Given this list of marker genes TMEM40, TPK1, SPACA6, TBC1D9B, CHAMP1, ZNF780B, APC2, CSNK1G1, ERF, ZNF564, ERCC6, RCHY1, CLEC11A, MGLL, HAUS3, TMEM184C-DT, PDGFA, DMAP1, OMA1, SPOCD1, ITGB3BP, FER, ZNF566-AS1, GLMN, TBX2-AS1, DGKA, CMC1, CAPN14, GREM1, TLCD5, MICD, SH2D5, PACS1, CCDC171, ZNF546, ZNF736, RN7SL685P, PLEKHM1, REXO4, GID4, MT-ND5, KARS1P1, DDHD2, THAP6, SMG5 (SMG5 nonsense mediated mRNA decay factor), RNF32, USP32, ZNF516, LAMA4, RHBDL1, PPP1R21-DT, CSPG4, C12orf76, SPTLC1P1, PNMT, POLE4, TPTEP2, GFPT2, RN7SL552P, RBM48, LGALS3, TTC23L-AS1, ENSG00000207751, ZNF384, ECI1-AS1, ST14, NPLOC4, ZNF234, JPH4, IPO5, SPEF2, LIM2, EPHX1, PEX5, PCLAF, SLC4A1AP (NCBI Gene Id 55189), PLEKHH2, SH3GL1, ZNF688, CPLX2, EMC4 (NCBI Gene Id 51234), CSK, VIRMA, WLS (Wnt ligand secretion mediator), LINC01168, CFAP418-AS1, ARFGAP2 (NCBI Gene Id 84364), MARCHF6, ESYT1, SLC35E1P1, RNU6ATAC34P, ENSG00000232995, DISC1, HNRNPR, MRPL55, APEH, CCNT2, STK19, AGPAT3, DDX31, ETFB, ABLIM2, COQ8B, TFEB, TNKS, PACRGL, ATP5PD, RAB11A, ERICH6, CCDC159, ODAD3, ISY1-RAB43, CUX1, SQSTM1, IDH1, DCTN2, LINC00847, SAP30L, NKPD1, USP8, LARP7, ZNF100, L3MBTL3, ZEB2, ABCA7, METTL9, NFATC4, ZNF568, ZNF227, PRCC, MGRN1, PICART1, TAFA2, WDR36, HS3ST3B1, PHLDA1-AS1, RIPOR1, ARID4B, WSCD2, TEFM, CNN3-DT, RBM42, ZNF146, SLC11A2, ZNF302, RNU6-234P, CAAP1, MICAL1, MPP7-DT, CCDC178, INO80D, RPL38, CEP192-DT, CAP1P2, LINC01273, ULBP1, CHRM1, FDFT1, KRT86, LIG4, TMEM184C, MTG1 (NCBI Gene Id 92170), DAP3, ZNF566, PCK2, ARHGEF10, OGG1, MDM2, MDM4, ULK1, CPXCR1, METTL4, PWWP3A, HMGB1, H3P10, ZNHIT6 (zinc finger HIT-type containing 6), KPNB1, DAD1, OSBPL11, TNFAIP1, ENSG00000272473, LINC00662, FRA10AC1, RNVU1-34, VIRMA-DT, SEC14L1, ABAT (NCBI Gene Id 731754), MRPL41, PHF3, SRRM2, CPNE1, VPS13B-DT, ZNF155 (zinc finger protein 155), ZNF569, LINC01972, ANGEL2, SLC9A7, USP15, CEP85, FGGY, MT-ND4L, SYNGAP1, TBPL1, CCN3, DPM3, ASGR1, DDX21, CFL1, NAA30, ELOC, RPL27A, MRPS31P5, KDM5A, LINC01549, MTF2, CYREN, FOXJ3, TTC41P, MAP3K14-AS1, ICA1L, ELAPOR1, SV2B, CRKL, STAT4, PTPRK, MTCL1, RSAD2, NDC80, ZNF25-DT, ALG10B, MAGOH2P, ANK2, GABPB2, CHUK-DT, ING2, TMEM225B, MPI, ZNF292, MSX1, CYP2F1, WDR11-DT, ZNF829, SRP54-AS1, EBNA1BP2, RNU6-362P, RMND1, RAB4B, ZNF540, DNAAF5, NADK, AFMID, HOXB3, NUDT3, KCNA1, LAMTOR5, ZNF233, PPIH, HMGN4, PPP1R21, MIR1301, SMYD4, RNU2-32P, MYLK, MAN2C1, PSMC3IP, TAOK2, SLC35E4, ATPAF2 (ATP synthase mitochondrial F1 complex assembly factor 2), NEO1, ALS2, REST, EXOSC3, CYP24A1, ERICH6-AS1, ACO1, MAX, TMT1B, LINC00173, ZC3H10, NR2F1, TTI2, COPS4, C8orf82, JPX (JPX transcript, XIST activator), ADGRF3, ZNF274, IFT20, MRPS31P4, ATP10D, MIR4794, SNRPCP3, RCAN1, ZNF33A, MIR3186, MIR9-1HG, CDKL2, FALEC, ACER3, NOTCH3, LINC01353, FAM8A6P (NCBI Gene Id 114182), DIS3L2, SULT2B1, MSRA-DT, MIR3677HG, TXNDC12, RNU6-738P, ILVBL, CCDC183, DIXDC1, ARHGAP1, MEIS1-AS2, HK2-DT (NCBI Gene Id 118568819), GPR146, RXFP4, RAI14, TMTC2, VWA8, EIF4G3, SLC39A3, NIM1K, PRKAG2, PSMD8, RPL6, SFXN1, SLC35A4, CTBP2P7, ENSG00000273523, TRPC6P2, SNX11, SLC12A7, MACROH2A2, MIR1193, LINC02361 (NCBI Gene Id 100996246), KCTD13-DT, CACNA1G, CCDC8, GBA1, EHHADH, SARS2, RELT, HACD3, AATBC, ZMPSTE24-DT, KLF13, BRD3, TGFA, MSMP, AATK, SHB, PKMYT1AR, NDUFA13 (NADH:ubiquinone oxidoreductase subunit A13), RPS27L, RPL12P37, ELFN2, RPS21P7, C1QTNF12, BIVM (NCBI Gene Id 54841), TASOR2, GALNT2, RPH3AL, PSMD6, HOXB-AS3, RNF145, TMEM69, ZNF37A, MIR663AHG (MIR663A host gene), ZNF433-AS1, SLK, RC3H1, TAF13, TPBG, ALOX12B, ZNF567 (zinc finger protein 567), ZNF438, LMNB1, FYCO1, GGT6, SAGE1, FKBP9, MORC2, RPL4, PMEPA1, DCAKD, HNRNPM, KCND3-AS1, PEX11G, ATP13A2, PRMT1, ZSCAN16-AS1, PML, ZBTB45, PLEKHG5, AKR7A2, SEPTIN5, BRD4, SMG1P2, DNAI4, SLC7A6, CBLN3, RN7SL45P, NR2E3, CDC42EP4, CISD1, HSP90B1, TTF2, STX1B, MCM3AP, NKAP, FRAS1, ZNF217 (zinc finger protein 217), ARB2A, TMEM70, NDRG2, CGGBP1 (CGG triplet repeat binding protein 1), RAD23B, KRR1, PIEZO1, MAGIX, CECR2, NDUFAF1, CFAP144, LRIG2, PCBP4, CNN3, ACD, LARP4, SSC5D, ZBED3-AS1, DPY19L3-DT, RDM1 (RAD52 motif containing 1), ENSG00000275465, BCAR1, HSPB1, ATG12, SREK1, MTA1, SFTPA2, RPS6KA4, KY, MSRA, PLCL2, FCHSD2, CATSPERG, LINC01475, CCDC106, GHITM, NDUFAB1, SMIM6, RAI1, CCDC142, EEF1D, MIR130AHG, CHGB, YAP1, EFCAB7, TTLL3, CHAC1, REV1, NFYC, CD37, TGFBR3, FIBCD1, LRP3, RIPK3, PPM1F, PIGK, ARHGAP40, ATP2B1, NOTCH1, ELOVL5, THAP8, CACNA1A, RNF215, FICD, ZNF331, CCDC88C, MAP3K14, LYPD5, HM13, ADGRG3, GMPPA, RBM19 (NCBI Gene Id 9904), HERC4, ACADL, TM9SF5P, LPP, DEGS1, C16orf87, F8, PPM1J-DT, PCYT2, TLNRD1, NPM3, IL27RA, PRR14, SRP14, CXXC1, LINC03047, GALK1, LRRC37A17P, ENSG00000260132, COPS3, DYRK1B, TNNI1, LIX1L, HTR1B, MISP3, SRRT, ECI1, ZWILCH, LINC01485, ZNF221, RAD52, UGT8, EML3, TAS1R1, CHMP4B, LINC01968, MARCHF2, TRNT1, TAL1, CARNMT1, EXO5-DT, PTCH2, ANKAR, KBTBD3, ENSG00000266313, SEMA6A (NCBI Gene Id 57556), CCAR1, RPS27, RUVBL1, NMNAT3, IMPA1, ZNF334, TOMM40, RWDD2A, EAPP, ZNF607, ZNF383, HAUS7, BCO2 (beta-carotene oxygenase 2), MIR3121, RASA1, VPS51, ANKRD20A5P, PPP6R1, RGMB-AS1 (RGMB antisense RNA 1), TMEM127, POLN, PGAP6, PPP2R3B, CREB3L4, ATG10-AS1 (NCBI Gene Id 100874022), LINC02598, VTA1, FHAD1, UBE4B, CORIN, BMP7, CCNT1, SLC35A3, OTUD5, BTBD2, TIGD6, ERBB2, FIRRM, TRIM24, ZNF382, TOR1AIP1, MRPL44, MAP3K9-DT, DBNL, AOC1, RCOR3, SERPINB1, PRAME, GOLPH3-DT, SNCAIP, PSMD3, BOC, LRRC32, ZNF491, MAD1L1 (mitotic arrest deficient 1 like 1), RPN1, PHOSPHO1, G3BP1, RPS27P14, LILRB4, KRTAP5-5 (keratin associated protein 5-5), DPF1, HOOK1, POLE3, ADNP2, TTC3, IPP, NALT1, FAM25EP, HIF3A, PRKAR1A, CTAGE13P, BLOC1S6, EXOC3, SIAH1, MIDN, PLAUR, GPC6, HLA-C, RNF126, FGFR1OP2, MANEAL, SEC14L2, NUDT15, EXD3, UQCC6, TOB1-AS1, RPL36P15, BCL2L1, EIF3F, CD101-AS1, CIZ1, MEF2C (NCBI Gene Id 4208), WDR31, ISL2, WDR62, SLC41A3, PGGT1B (protein geranylgeranyltransferase type I subunit beta), PDXDC1, BRD9, ARHGEF19, EVA1CP5 (NCBI Gene Id 122149298), IGDCC4, MROH5 (maestro heat like repeat family member 5 (gene/pseudogene)), GSK3B-DT, LINC02259, HMGN3-AS1, SDC1, USPL1, CUTA, ZNF764, PIERCE1, GIN1, SUB1, ARMT1, ABT1, IDH2, ZBTB25, CADPS, TSN, FUT10, BIRC6, LGI1, SAR1B, SAMD4B, PDCL3, DPY19L2P1, INTU, SLX9, PLK2, FKBP1A, ADPGK, WDR11, PITHD1, PARP16, C6orf226, CROCC2, ANK1, GPBP1L1, DGKD, UBE2Q1, LCOR, TMBIM4, FOXD3, CLK2, LINC01278, TAGLN2, CD177, TMC4, CCDC77, POLR3A, CPAMD8, TCF3, PRKN, THRA, ZMAT4, GSR, MRPS12, NOL9 (nucleolar protein 9), ENSG00000272195, KIF9, KCTD15, ZFP28-DT, ARHGEF7, ZNF321P, POLE2, PEPD, RAD51D, NEMP1, ELF1, DDX41, ZNF341-AS1, ANKRD13D, TBCA, ZFP82, SH3D21, NR1I3, VPS13B, TRIP12, LINC01719, TK1, C19orf12 (NCBI Gene Id 83636), MLXIPL, UBE2D3, ENSG00000272008, TAC1, RGS5, SELENOI, SAMD12-AS1, DNAJC25-GNG10, UBA1, SCGB2B2, CBLB (Cbl proto-oncogene B), SH2D6, MPO, PKMYT1, FAM185BP, PBX1-AS1, NARF, GDNF, GPS2, PLPP7, IQSEC2, SULT1A2, RPA1 (replication protein A1), ZMYM1, CENPT, TRIM31, PPM1J, ANAPC5, RILPL1, AMDHD1, PURPL, BARX1, TMEM68, GAS8, CRHR2, SUPT7L, ZFR, ZNF189 (NCBI Gene Id 7743), RNF170, BNIP1, KCNK1, RPLP0P6, ANKRD16 (ankyrin repeat domain 16), PARP2, DEAF1, RNU12, MKNK2, YTHDC2 (YTH N6-methyladenosine RNA binding protein C2), KALRN, PPP1R18, CFAP298-TCP10L, ARFGEF1, TIMM50, TMEM79, MTR, SENP6, BMPER, KCTD2, PARD6A, ETV3, ENTPD6, DTD1, KCNAB1, STAT3, WDR24 (NCBI Gene Id 84219), MLF2, EMX1, NAE1, CASP7, MTCO3P12, ZNF585A, EHMT1, KIF21B (NCBI Gene Id 54770, kinesin family member 21B), CDC42SE1, PLCG2, STK11IP (NCBI Gene Id 114790), FBXL19, CCDC38, ZC3H6, TNPO1-DT, SERPINA6, NAA15, CCDC93, ATF7, LINC01547, SLC5A8, ENSG00000302878, DIAPH1, PIKFYVE, MIR7-3HG (NCBI Gene Id 284424), DPY19L3, EHD3, ZNF248-AS1, PSMB4, EFCAB13-DT, POP4, TCF7, VDAC1, APBB3 (amyloid beta precursor protein binding family B member 3), CIMAP1C, DAB1, LRRC8A, SPOCK2, MTMR9, ENTPD2, XYLT1, FAM222A, MYBBP1A, MIS18BP1, FRMPD4, SLC22A23, REPS1, PKIG, CNIH3, SOAT1, EBF2, TSSK3, LRRFIP1P1, GOLGA7, LRRC20, PFAS, TMEM242, DNAJC3, RNVU1-31, LRRC37A5P, STOX2, PDK2, STK24, ANKRD40, STUM, MMP25, SRP54, NCBP2, PLK1, ZNF780A, RAVER2, KANSL1-AS1, GATAD1, TNIK, LYPLA1, CLBA1, KHNYN, RBM12, MUS81, FAM227B, COL4A1, PA2G4, NUP62, SLC25A30, TRIP10, MAPK1IP1L, PPP2R2A, MFAP4, SMAD4, PTPRG-AS1, DENR, CCNG1, CCDC162P, EMID1, MRPL28, PRPSAP2, LINC02332, DTWD1, PLAAT3, ABHD14A-ACY1, TTI1, ARID3A, TRIM52, RPL27, ANKRD28, DTNBP1, SELENOH, CHCT1, GABPB1-AS1, CFAP298, ZDHHC12, ICA1-AS1 (ICA1 antisense RNA 1), LAMB1, HPS4, MIR638, CD46, MAP3K7CL, TLE7, TARS2, VDAC2, TRAFD1, ZNF451, SLC44A1, TMEM169, CDHR2, YTHDF2, HS3ST3A1 (heparan sulfate-glucosamine 3-sulfotransferase 3A1), OSBP2, AASDHPPT, PLD4, ZNF330, KIAA0930, MAP3K21, PDLIM7, RHOC, TMEM43, SPESP1, NFIA, SP1, FOXL1, ANXA2, FBXO27, SYNGR2, TBC1D19, CASZ1, MED26, MGAT4B, TMA16, LSP1, RAB34, FAM169A, SRP14-DT, TMC3-AS1, MT-RNR1, TEX22, MIEF2, SEC1P, ISYNA1, MT-ND4, APBA1, URI1, INTS11, DNAI1, ASCC1 (NCBI Gene Id 51008), MIR6826, ABHD14B, DOLPP1, RNF217, ALDH16A1, SUGT1P4-STRA6LP, NEIL1, ABALON (apoptotic BCL2L1-antisense long non-coding RNA), SERF2 (NCBI Gene Id 88287), IGFLR1, CCDC146, TBC1D26, PIP5KL1, PRB2, MIR200CHG, NUTF2, KRTDAP, DCLRE1B, SNRPB, ENO3, DCLRE1C, ITGAE, FGF13, KDM6B, DNM1P35, PIWIL4, RRAGAP1-AS1, NEDD1, RNU1-149P, RNF186-AS1, ZNF565, TRIP13, ZKSCAN8, SRSF9, ATG7, POLDIP3, KAT6B, CITED2, MRPL50, SCO1, INO80C, NDUFC1, GP6, ZNF793-AS1 (NCBI Gene Id 101927720), MMP14, GTDC1, TIPIN, FGF1, PYCR2, SCAND3, NCKAP1L, TIAM1-AS1, TRIP4, FNDC3B, FOXG1, FAN1, SLAIN2, RILPL2, ZNF56P, DLL3, DLEU1, CPNE8, MAP3K9, NIPSNAP2, RPL7P3, ZNF16, PIGN, DAAM2, CLSTN1, MCCC1, ENSG00000255647, ETV5, TNPO2, LINC02997, NADK2, ZSCAN26, VGLL4, RFTN1, ABHD5, CMPK2, CASKIN2, ANLN, ZBTB26, LMNB1-DT, E2F8, BAP1, GULP1, RPL7AP12, SKIC8, EAF1, NUDT14, EXO5, SPATA33, MAP3K11, CD209, GUCA2A, ANAPC16, RPRD1B, GFI1B, POLL, ANP32A, DRG2 (developmentally regulated GTP binding protein 2), GNAL, SMARCD2, ISLR2, ARL14EP, ZMPSTE24, STARD3NL (NCBI Gene Id 83930), LINC00311, DXO, GALNT1, AP3S2 (NCBI Gene Id 8885), ZNF773, LINC01877, STRN3, CORO2B, ICA1, RELCH, ARFGEF2, ZNF260, ZNF585B, TFAP2A-AS1, CD68, ADORA1, ARFGEF1-DT, CHMP1B, SLC9A5, LPCAT3, WT1, TPRA1, SLC43A2, ERVK3-1, LRRC8E, ENSG00000275765, ZNF48, TIGIT, TMEM186, IL9R, L3MBTL1, FUNDC2, METTL21A, TYK2, RNVU1-7, VPS26C, NEU1, EVA1CP4, GPM6B, ZNF284, ADAP2, FAM149B1, GGPS1, PEAR1, TOB1, UBFD1, RPS7, ZFP36L1, MIR7-3, YOD1, HMGCLL1, LINC01836, MRPS21, GPR161, LAT, SDHAF4 (succinate dehydrogenase complex assembly factor 4), UGT3A2, INPP4A, MT-TF, ETNK1-DT, STARD5, MHENCR (NCBI Gene Id 100505771), RC3H1-DT, LRRC34, C1orf159, CLN6, MAP3K10, FNIP1, CLN3, MTND5P11, SLC22A17, LAMP1, ZNF786, LAMTOR5-AS1, C19orf47, DAZAP2, PIAS4, EIF4E1B, EVA1CP3, APRG1, CENPU, GTF3C3, TCEA3, CMTR2, INTS14, MT-TS2, WNT7B, ECD, C1orf131, MIA2, MAN1C1, LRRFIP1, GNG4, LZTS2, ZNF667-AS1, EFR3B, GABPB1, CFAP276, DNM2, TTC28, PGM2, LINC00652, MTIF3, HNRNPL, LINC00598, KIAA0232, RPPH1, TCEANC, LTBP4, ANKRD12, CTSB, HRK, MEX3C, FAM117A, ZNF485, TRAJ29, RNVU1-29, ACTN2, COX7C, ERRFI1, SPTBN4, ETNK1, MTHFR, MSL2, KILH, LINC02739, ZFP14, ENSG00000260830, ZNF573, TNPO1, ESR2, IQGAP2, PDE9A, EIF2D, MPPED2, FASTKD5, MADCAM1, GARRE1, LINC01166, PLK5, AGBL4, ZGRF1, CDKN2A, CYP2S1, AGRN, TENT5C, CRAT (carnitine O-acetyltransferase), MGAT4A, RNU2-37P, TAF1A, TSC1, STK10, FHOD1, MEF2C-AS2, ZNF605, SDCBP2, ZNF83, ACOX2, ABCF1, EEF1A2, SUCLG2P2, CEBPG, COX16, KANSL1, FOXF1, DNAJC3-DT, PAFAH2, DNASE1L2, SORL1-AS1, ARL4C, SLC66A1, SPPL2B, GNAS-AS1 (GNAS antisense RNA 1), NPHP4, RPS19, MTRR, MTHFD1, CRACR2B, EFCAB2, ZNF180, C14orf28, E2F3, PHF21A (NCBI Gene Id 51317), HECTD2, LGMN, YBEY, PPIP5K2 (NCBI Gene Id 23262), ENSG00000275527, PNPLA7, CUL1, BCRP2, MAFK, PCK1, ATP13A1, CERS2, ABR, SLC25A15P2, GAS7, SPANXB1, TACO1, TMEM275, TPPP2, FOXG1-AS1, BTN1A1, THAP10, SAMD11, INHBE, ZNF888-AS1, EIF4EBP3, TREX2, VWA8-AS1, ZKSCAN4 (zinc finger with KRAB and SCAN domains 4), GOLM2P1, HINT1, RBBP5, TMEM41B, MIR4634, B4GALT4, EIF5, EPS8L2, HGSNAT, SP140, ABI2, GIPC1 (NCBI Gene Id 10755), EPB41L3, GABBR1, ZNF337, MED23, PRKCSH, CFAP57, BACH2, DENND1C, ZZZ3, GPRIN3, ZNF345, UBN2, CD200, MRPS31, USP30, ZNF131, COMMD4, WAPL, PECR, PSME3, GLT1D1, CDH24, KCTD13, PDE11A (NCBI Gene Id 50940, phosphodiesterase 11A), ARID2, ASXL1, IL32, SCRN3, PPP4C, ZNF420, TGS1, MPC1, NT5C2, LINC00663, SPTAN1, CETN3, ELL3, GCLC, POLR3B, MRPS2, PSPN, GCC2, AGL, UQCRC2, ENSG00000253740, PHAF1, EBPL, EOLA1, CEP15, LINC00945, WDFY1, CPLANE1, WDR5, CDHR1, CHFR, DPCD, RNF10 (NCBI Gene Id 9921), PIP4K2A, TOB2, SUPT16H, CDCA4P1, SF3B6, GEMIN5, LINC02412, IRAK1BP1, SNX31, TBCD, RUSC1, ALKBH3, AMOTL2, GTF2I, PDCD6P1, RBM6, SEMA3A, ALDH18A1, CALCB, EARS2, IPO8, MORC3, GEMIN8, UNC13D, C3orf38, LINC01535, ZNF408, MYCBP2, RNPEP, SUGT1P1 (SUGT1 pseudogene 1), CCDC3, ZNHIT2, SFTA1P (NCBI Gene Id 207107), HK2, ZNF529, CES1P1, VGLL2, ATG4D, TP53, CYP2E1, RNU1-11P, NCOA2, PTPN13, ARL6IP1, ZNF609, PACRG, MIR5588, ZNF675, TFRC, IL15RA, NEK5, SRCAP, DLAT, ALDH1A2, CDIP1, ZNF160, HDAC7, ZNF805, GRM8, MKLN1, CENPJ, BBS4 (Bardet-Biedl syndrome 4), SPACA5, KXD1-AS1, ST6GALNAC6, ELL2, IL5RA, PLCD1, TALDO1, HOOK3, RPL37, ING3, LITAF, WAPL-DT, MIR301B, NCBP2AS2, PAOX, CPSF1, CDK5RAP1, TBP, PCYT1A, STXBP2, ANO8, GNAS, TUG1, TMEM59L, ISY1, LINC01359, ANXA2R-AS1, CCDC57, SOX3, ZNF587B, CYP17A1, MMP13, ZNF570, ZC4H2, GMEB2, NPM1P37, TOP3B, OSM, MRPS17, SLC24A1, SEMA4B, ZNF767P, ZNF667 (NCBI Gene Id 63934), TEX46, WRAP53, FBXO36, LINC01818, LINC02773, DNAJC25, AMD1, TMEM242-DT, RND3, FBXL20, PMM2, LINC01937, ALDOA, DNM1, APC, NUF2, GTPBP3, YY1AP1, ZFP30, KLF4, AURKAIP1, MT-TH, LGR6, ENSG00000259754, FUT4, EFCAB14, RGMB, ZNF461, ENSG00000244137, PDPR, LINC01515, ZBTB1, PXDN, ENPP3, PIF1, CEP192, LINC01087, HDAC1, GOLPH3, NAV1, CYCSP20, INTS13, ZNF248, DPEP1, TTC23L, ZNF567-DT, YPEL4, FAM228B, PYM1, SLC22A16, PRELID3BP3, GOPC, XPO5, PIH1D1, UBOX5, SUGT1P4-STRA6LP-CCDC180, SOX13, PFN1, HLA-DQB1, PCGF5, U2AF2, RNU6-759P, BCAS4, SUGT1P4, ATF7-NPFF, NOL4, TAF15, SRPRB, PLD3, BAIAP3, ZNF846, MIR1302-3, C1orf74, LRRC49, SEC22B, SDCBP, ZCWPW1 (zinc finger CW-type and PWWP domain containing 1), BICDL3P, ATP6V0D1, SNX13, PKD2L1, ARHGAP42, MAP3K12, ADGRA2, MT-TL2, ZFP28 (NCBI Gene Id 57588), ZNF385C, ABHD14A, AK5, RUNX1, LINC00665, CA5B, PIK3CA, IL6R, ZNF790-AS1, FENDRR, IFI6, PRND, ZNF254, MIA2-AS1, SLC66A3, RNF40, LCDR (lysosome cell death regulator), CROCC, PAM16, FAR1, LINC02447, POMP, ODF4, YWHAQP7, DDX47, KRT32, ABCC8 (NCBI Gene Id 6833), PLPP2, EIF5A, C20orf141, TIE1, FAM111B, PDXK, POGLUT3, LINC03019, PINK1, KYAT1, ZNF599, CCDC91, MIR4270, EGLN2, GSDMB, CCDC66, SCN8A, RNU1-6P, TSSK6 (testis specific serine kinase 6), ENSG00000267568, RNU6-307P, ROBO1, AK1, CUL2, ZNF793, MTERF4, CAMLG, ZNF790, RLF, MCCC2, CNRIP1, FOXD3-AS1, C9orf43, DBP, CIT, RPGRIP1, AGER, ZDHHC12-DT, ZDHHC14, PICSAR, DNAJC6, CEMIP, HDGF, RNA5S17, ACTR3, DCLK1, NARF-AS2, COMMD4P1, TDG, C6orf136, LINC00114, LINC02987, CLUL1, BTF3L4, ZNF182, PTPN11, ANXA8, FBXO22, WT1-AS, LINC01596, AP3S1, FCN2, TSEN54, ZNF134, here is a description of the gene set: Human Gene Set: ZNF320_TARGET_GENES species: Homo sapiens from publication Yevshin I, Sharipov R, Kolmykov S, Kondrakhin Y, Kolpakov F (PMID 30445619)